Given this list of marker genes SIRT5, SIRT4, SIRT1, SIRT3, SIRT6, SIRT7, SIRT2, here is a description of the gene set: studied in species Homo sapiens Human Gene Set: GOMF_NAD_DEPENDENT_PROTEIN_LYSINE_DEACYLASE_ACTIVITY Catalysis of the reaction: N6-acyl-L-lysyl- + NAD+ + H2O = 2''-O-acyl-ADP-D-ribose + nicotinamide + L-lysyl-.